Given this list of marker genes SLC2A1, PDP1, PFKP, PDK1, HK1, LDHA, PKM, SLC16A1, here is a description of the gene set: studied in species Homo sapiens Human Gene Set: WP_GLUCOSE_METABOLISM_IN_TRIPLENEGATIVE_BREAST_CANCER_CELLS Glucose metabolism in triple-negative breast cancer cells